Given this list of marker genes PPP3R1, PSMB5 (NCBI Gene Id 5693), MUC15, MALT1, MUC20, PSMB1, UBE2V1, UBE2D2, PSMC6, CDC34, MUC3A (NCBI Gene Id 732156), MUC1, ITPR1 (inositol 1,4,5-trisphosphate receptor type 1), PSMD6, HRAS, MUC5B, MUC4, UBB, CHUK, TAB2, SEM1, PRKACB (NCBI Gene Id 5567), RELB, MUC21, PPP3CB, CALM1, PSMD1, PSMD11, EP300, PSMC3, PSMA3, PSMB3, UBC, PSMD3, PSMD12, UBA3, PRKACA, NFKB2, RPS6KA5, RPS27A, NFATC3, PPP3CA, MUC13, AHCYL1, MUC17, MUC7, CCL22, PSMC1 (proteasome 26S subunit, ATPase 1), FYN, PSMB7, PSMB6, BTRC, PDPK1, ITPR2, ICAM3, PAK1, RAF1 (Raf-1 proto-oncogene, serine/threonine kinase), PSMB2, LYN, CARD11, MUCL1, SYK, FCER1G, MUC5AC, PYCARD, PSMA7, NFATC2, PRKCD, BCL10, ADRM1, CLEC4A, SRC, SKP1, TAB1, NRAS, CLEC4D, IL1B, IKBKG, UBE2M, CD209, RELA, PSMA4, CLEC4E, PSMC4, CASP8, IKBKB, PSMD2, CARD9, UBE2N (NCBI Gene Id 7334), CLEC4C, NFATC1, PSMB4, MUC12, PSMC2, UBA52, ITPR3, MUC16, PAK3, PSMA2, PSMD8, TAB3, PLCG2, CUL1, CCL17, CLEC10A, PAK2, NFKB1, ICAM2 (intercellular adhesion molecule 2), PRKACG, NFKBIA, MAP3K14, PSMD13, FBXW11, CREBBP, PSMD7, MUC6, CLEC6A, PSMC5, PSMA1, MAP3K7, CLEC7A (NCBI Gene Id 64581), TRAF6, PSMA6, PSMA5, KRAS, UBE2D1, PSMD14, here is a description of the gene set: C-type lectin receptors (CLRs) Human Gene Set: REACTOME_C_TYPE_LECTIN_RECEPTORS_CLRS species: Homo sapiens